The following is a description of a gene set: studied in species Homo sapiens The formation of a protein tetramer, a macromolecular structure consisting of four noncovalently associated identical or nonidentical subunits. Human Gene Set: GOBP_PROTEIN_TETRAMERIZATION, and this is the list of marker genes: CRTC2, GLS, SHMT2, GRIN1, TP63, THG1L, RYR3, KRT10, SOD2, FKRP, AQP2, SYCP1, RRM1, TRPA1, HLA-DRB1, TRPV5, TRPM7, KCNT1, STK4, ACACB, USP16, GNMT, AQP4, PKD2, ITPR3, SNUPN, DEFA5, KCND3, VASP, EVL, CBR4, KCNC3, OSBPL2, CUTC, TDO2, PKD1, UPB1 (NCBI Gene Id 51733), CRTC3, ALDH9A1, COL6A1, ALDOA, PKD2L1, STK3, FARSB (phenylalanyl-tRNA synthetase subunit beta), SAMHD1, NUDT21, TRPM6, MS4A1, HPRT1, ME1, DNM1, AQP10, TRPM2, PEX5, GOLGA2, HOMER1, SSBP1, ITPR1, CRTC1 (NCBI Gene Id 94159), SHMT1, KCNJ12, APP, ALDH1A2, HSD17B8, KIF25, APPL2, ACACA, MCOLN1, FARSA, ALDH1A3, TK1, CBY1, MAT1A, KCNC1 (NCBI Gene Id 3746), GRIN2B, CTH, APIP, TRPM4, HCN1 (NCBI Gene Id 609), CPSF6, CPSF7, TRPM1, CRYZ, RYR1, TRPV1, ACOT13, B2M, GRIA3, GBP5, RRM2, TP53, AQP5, HSD17B10, SNCA, KRT1, TP73, TRPM3, KCNN4, OXA1L, KCNJ2